Given this list of marker genes ADAMTS9, BLOC1S5, ZEB2, ADAMTS20, BCL2, BLOC1S6, KITLG, GNA11, here is a description of the gene set: Human Gene Set: GOBP_REGULATION_OF_PIGMENT_CELL_DIFFERENTIATION species: Homo sapiens Any process that modulates the frequency, rate or extent of pigmented cell differentiation.